Given this list of marker genes Cav1, Cav3, Atp2b4, Snca, Gla, Nfkb1, Eng, Cyp27b1, Gfi1, Nosip, here is a description of the gene set: Mouse Gene Set: GOBP_NEGATIVE_REGULATION_OF_MONOOXYGENASE_ACTIVITY Any process that stops or reduces the activity of a monooxygenase. species: Mus musculus